Given this list of marker genes RFC2, BRD4, TCF20, RPS7, ROR2, SYT1, NODAL, VPS35L, CDCA7, FGD1, DDR2, MYMK, GMNN, ACTB, VPS53, DISP1, LONP1, HDAC6, FLII, SMARCA2, RNU4-2, ZSWIM6, APC, ALG9, FZD2, CASK, SIX3, TAF6, NALCN, WNT5A, PPP1R12A, PIGN (NCBI Gene Id 23556), CRIPTO, EHMT1, SIN3A, RPS6KA3, ERCC2, MAP2K2, TONSL, HNRNPK, RFX7, DPYSL5 (NCBI Gene Id 56896), METTL27, KDM6A, PLAA, ALDH6A1, DPF2, ATAD3A, PAM16, GJA1, SCN4A (sodium voltage-gated channel alpha subunit 4), NIPBL, WAC, FKBP6, IQSEC2, DNAJC30, STAMBP, TRRAP, NRCAM, NARS2, RNF13, PURA, COG8, TRIP12, SON, BMPER, TMCO1, PUS1, ATRX, HDAC8, BUD23, WASHC5, ADAT3, RAB3GAP2, YARS2 (tyrosyl-tRNA synthetase 2), TRIP11, KIF7, TMEM94, PIGV, MN1, SOX11, PIGF, PHIP, FLNA, TBL2, SLC26A2, PGAP3, SHH, RECQL4, SNRPN, ANTXR1, CDH11, SMAD2, PEX6, HRAS (NCBI Gene Id 338029), POLR1A, SMC3, IL1RAPL1, PTEN, MIR140, NEDD4L, CACNA1G, KMT2D, ASXL3, B3GLCT, DVL3, ZBTB24, PPP1R15B, DCPS, MYCN (MYCN proto-oncogene, bHLH transcription factor), GTF2I, CHST14, INTS1, PAX3 (NCBI Gene Id 5077), DLL1 (delta like canonical Notch ligand 1), ATP6V1E1, MAF, POLA1, AGO1, BAZ1B, FBXO11, TGIF1, ZMPSTE24, PARS2 (NCBI Gene Id 91517), SLC25A24, SMARCB1, PRMT7, DHCR24, CLIP2, STX1A, DDB1, HECTD4, TAPT1, FAR1, DYRK1A, GATA4, LMNB1, GPC4, MEF2C, PEPD, COL2A1, HSPA9, MYMX, INPPL1, TRMT10A, LTBP3, EBF3, TMEM270, BCAP31, PUF60 (NCBI Gene Id 22827), PDE4D, TBL1XR1, CDON, MPLKIP, MED13L, ADSL, AGA, AFF4, GLUL, FBN1, HEPACAM, HIC1, DPYD, PPP1R21, FGFR2, PPP2R5D, ZNF699, ATP6V1A, MOCS1, PAK3, COG7, B3GALT6, CD96, SMARCD1, DNMT3B, MADD, PLA2G6, WNT7A, PGAP2, NEXMIF, FUT8, ZMYM2, RAD21, BUB1B, RAI1, EIF4H, CEP57 (NCBI Gene Id 9702), ABL1, ATP6V0A2, CREBBP, FGFR1, NFIA, RAB18, SMC1A (NCBI Gene Id 8243), POR, MTOR, DEAF1, NAA10, ADNP, GLI3, KMT2A, ELN, TCTN2, BRAF, ZNF462, HOXB1, GNAI1, ZIC2 (NCBI Gene Id 7546), TRIO, ABCC8, SPOP, SATB2, NPR2, GTF2IRD1, EFTUD2, VARS1, GBA1, GAS1, KRAS, DDX3X, BMP2, NCAPG2, PIGO, EDA, BLTP1, GPC6, CHSY1, RAB3GAP1, SMOC1 (SPARC related modular calcium binding 1), PTH1R, NXN, ADAMTSL2, VPS37D, FAM20C, MOCS2, RAC3 (NCBI Gene Id 5881), SMARCA4, FOXG1, SMO, CCDC22, TCTN3, MYH3, ARSL, ECE1, COX7B, CLP1, GTPBP2, NCF1, GRIN2A, ARID1B (AT-rich interaction domain 1B, NCBI Gene Id 645070), GPC3, PAICS, DVL1, BMP4 (NCBI Gene Id 652), SPECC1L, SOX4, EXTL3 (NCBI Gene Id 2137), ARID1A, ZPR1, LIMK1, FLI1, GGCX, FOXH1, PYCR2 (NCBI Gene Id 29920), MBD5, CNTNAP2, AVP, SLC35D1, LIFR, CANT1, CTCF, NRAS, FOXP1, PAFAH1B1, MLXIPL, PIGU, MAP2K1, DSE, SUFU, GNB2, GTF2IRD2, PRPS1, USB1, UBE3B, SETBP1, SC5D, PPP1CB, POU1F1, COL11A2, ARID2, DIS3L2, PDGFRB, SLC2A10, UBR1 (ubiquitin protein ligase E3 component n-recognin 1), HUWE1, SLC12A6, FGF8, GLI2, KCNJ11, TXNL4A, SMARCC2, SHOC2, ABCD1, PLOD3, COL11A1, CAV1 (caveolin 1), PLCB3, SPTBN1, VPS33A, RSPRY1, NFIX, LRP2, CCDC88A, IARS2 (NCBI Gene Id 55699), PIGT, SMARCE1, FLNB, PRKAR1A, RIPK4, ZNHIT3, DPM2, TBC1D20, PTCH1, MARS2, YWHAE, LRP4, CDKN1C, BPNT2, here is a description of the gene set: Distance from nasion to subnasale more than two standard deviations below the mean, or alternatively, an apparently decreased length from the nasal root to the nasal tip. Human Gene Set: HP_SHORT_NOSE species: Homo sapiens Short nose